Given this list of marker genes Rps27a, Jup, Ctss, Ctnnb1, Cdc42, Cdh1, Ubb, Cbll1, here is a description of the gene set: This event has been computationally inferred from an event that has been demonstrated in another species.<p>The inference is based on the homology mapping from PANTHER. Briefly, reactions for which all involved PhysicalEntities (in input, output and catalyst) have a mapped orthologue/paralogue (for complexes at least 75% of components must have a mapping) are inferred to the other species. Reactome Pathway: SRC activates STAT3 in a quantitative manner, through Cadherin-11 (CDH11), RAC1 and gp130 (IL6ST) species: Mus musculus electronically inferred by orthology from the curated human pathway part of: Activation of STAT3 by cadherin engagement